Given this list of marker genes UTP25, RRS1, RRP36, NOL10, HEATR1, ERCC2, RPS19 (NCBI Gene Id 8378), RCL1, TSR1, ABT1, UTP23, UTP6 (NCBI Gene Id 55813), UTP20, TSR2, GTF2H5, DCAF13, FCF1, UTP3 (UTP3 small subunit processome component), RPP40, BMS1, NGDN, NOP14, PWP2, NOP9, SLX9, WDR43, BYSL, DHX37, RPS21, UTP4, WDR46, TBL3, RPS8, RPS16, KRI1, here is a description of the gene set: Human Gene Set: GOBP_MATURATION_OF_SSU_RRNA_FROM_TRICISTRONIC_RRNA_TRANSCRIPT_SSU_RRNA_5_8S_RRNA_LSU_RRNA Any process involved in the maturation of a precursor Small SubUnit (SSU) ribosomal RNA (rRNA) molecule into a mature SSU-rRNA molecule from the pre-rRNA molecule originally produced as a tricistronic rRNA transcript that contains the Small Subunit (SSU) rRNA, 5.8S rRNA, and the Large Subunit (LSU) in that order from 5' to 3' along the primary transcript. species: Homo sapiens